Given this list of marker genes G0S2, C1QTNF2, LYZ, BAMBI, MMP11 (NCBI Gene Id 4320), RAB3D, WNT4, PDLIM2, TMEM178A, SLC16A9, ATOH8, GDF10, PLEKHA6, DBP, CORO2B, PALM, ABLIM1, SEPTIN4, SELENBP1, GSTT1, SYNPO, BMF, SUCNR1, here is a description of the gene set: Genes down-regulated in hepatic stellar cells after stimulation with bacterial lipopolysacharide (LPS). Human Gene Set: SEKI_INFLAMMATORY_RESPONSE_LPS_DN species: Mus musculus from publication Seki E, De Minicis S, Osterreicher CH, Kluwe J, Osawa Y, Brenner DA, Schwabe RF (PMID 17952090) Hepatic injury is associated with a defective intestinal barrier and increased hepatic exposure to bacterial products. Here we report that the intestinal bacterial microflora and a functional Toll-like receptor 4 (TLR4), but not TLR2, are required for hepatic fibrogenesis. Using Tlr4-chimeric mice and in vivo lipopolysaccharide (LPS) challenge, we demonstrate that quiescent hepatic stellate cells (HSCs), the main precursors for myofibroblasts in the liver, are the predominant target through which TLR4 ligands promote fibrogenesis. In quiescent HSCs, TLR4 activation not only upregulates chemokine secretion and induces chemotaxis of Kupffer cells, but also downregulates the transforming growth factor (TGF)-beta pseudoreceptor Bambi to sensitize HSCs to TGF-beta-induced signals and allow for unrestricted activation by Kupffer cells. LPS-induced Bambi downregulation and sensitization to TGF-beta is mediated by a MyD88-NF-kappaB-dependent pathway. Accordingly, Myd88-deficient mice have decreased hepatic fibrosis. Thus, modulation of TGF-beta signaling by a TLR4-MyD88-NF-kappaB axis provides a novel link between proinflammatory and profibrogenic signals.